Given this list of marker genes Fam53c, Tbc1d9, Nudt5, Dnai3, Mfsd6, Elavl2, Camk2a, Trib1, Gnptab, here is a description of the gene set: from publication Chen Y, Wang X (PMID 31504780) species: Mus musculus Mouse Gene Set: MIR_7675_5P Genes predicted to be targets of miRBase v22 microRNA mmu_miR_7675_5p in miRDB v6.0 with MirTarget v4 prediction scores > 80 (high confidence targets).